The following is a description of a gene set: Any process that stops, prevents, or reduces the frequency, rate or extent of phosphatidylinositol 3-kinase/protein kinase B signal transduction. Human Gene Set: GOBP_NEGATIVE_REGULATION_OF_PHOSPHATIDYLINOSITOL_3_KINASE_PROTEIN_KINASE_B_SIGNAL_TRANSDUCTION studied in species Homo sapiens, and this is the list of marker genes: MIR375, LEMD2, DLG1, SIRT1, TSC2, MIR145, OTUD3, HYAL2, NHERF1, PIP5KL1, GPER1, PIK3IP1, USP49, MIR146A, PKHD1 (NCBI Gene Id 5314), DRD2, BTN2A2, PPARA (peroxisome proliferator activated receptor alpha), DAB2IP, SFRP5, HLA-G, MTM1, INPP5E, RUBCN, NLRC3, CRYBA1, NOP53, ARRB2, MIRLET7F1, PHLPP1, PHLDA3, DRD3, PTPN1, MMP3, THEM4, DDIT3, PPP2R1A, MIR34B, FLCN, RACK1, MIR206, SH2B3, SIRT7 (NCBI Gene Id 51547), LOX (lysyl oxidase), DAG1, KLF4, TWIST1, MIR20A, CAVIN3, EPHA7, PDCD6, STAMBP, SERPINE2 (NCBI Gene Id 5270), PLK3, MIR34C, MSTN, MAGI2, PLEKHA1, PTPRJ, INPP5K, BANK1, CIB1 (NCBI Gene Id 10519), PIK3CB, MIR29B1, MUL1, PTEN, PPP2CA, MIR34A, TREM2, AIM2, SMPD3, MIR29C, MIR449A, WDR91, MIR29A